Given this list of marker genes Cdc42, Syk, Arpc4, Nf2, Pik3cb (phosphatidylinositol-4,5-bisphosphate 3-kinase catalytic subunit beta), Fgr, Wasf3, Grb2, Ptk2, Wasf1, Nckipsd, Plcg2, Vav1, Igll1, Actr2, Cd3g, Actr3, Crk, Arpc5, Yes1, Pld2, Arpc2, Pld3 (NCBI Gene Id 18807), Pik3r2, Cyfip2, Pla2g6, Fyn, Mapk3, here is a description of the gene set: Reactome Pathway: Fcgamma receptor (FCGR) dependent phagocytosis electronically inferred by orthology from the curated human pathway studied in species Mus musculus This event has been computationally inferred from an event that has been demonstrated in another species.<p>The inference is based on the homology mapping from PANTHER. Briefly, reactions for which all involved PhysicalEntities (in input, output and catalyst) have a mapped orthologue/paralogue (for complexes at least 75% of components must have a mapping) are inferred to the other species. part of: Innate Immune System